The following is a description of a gene set: We sought to identify genes regulated by the transcription factor Th-POK (Zbtb7b) in liver Va14i NKT cells, by RNA microarray analysis of global gene expression in Va14i NKT cells from mice homozygous for the Th-POK-inactivating hd point mutation as compared with the same cell population isolated from heterozygous or wild-type age-matched mice. from publication Engel I, Zhao M, Kappes D, Taniuchi I, Kronenberg M (PMID 23034280) Genes down-regulated in Va14 invariant NKT cells: ZBTB7B knockout versus wildtype. species: Homo sapiens Human Gene Set: GSE34179_THPOK_KO_VS_WT_VA14I_NKTCELL_DN, and this is the list of marker genes: FSCN1, TM4SF4, KY, WWC1, LIF, ADM, IL2RA, EBF1, DPAGT1, MPEG1, CCT2, LAMC1, C3, PAK5, IRF8, MTHFD2, BCL11A, AKR1D1, TEKT2, PRKCSH, GADD45B, SUV39H2, NDFIP2, C6orf118, THOC1, FOS, CCDC159, ZNF473, H2AZ1, CA12, TCEAL8, CCNK, NCS1, TAF2, TFRC, BRCA1, HEPACAM2, VPREB1 (V-set pre-B cell surrogate light chain 1), POLR2G, SLC22A23, RRM2, DUT, ODF1, GLRX5, ATAD5, CCR8, TEFM, BCAP29, CCL4, PLEK, TOP2A, NR4A1, IL1RN, CTPS1, KCNF1, CYP11B2, TIMM8A, FNDC3B, EGR3, SPRY1 (sprouty RTK signaling antagonist 1), HAVCR1, CARMIL1 (capping protein regulator and myosin 1 linker 1), LAD1, BCAT1, TNFRSF13C, ZKSCAN8P1, DUSP5, ANKRD13C, BCL2L1, EGR1, SCARB1, TSPAN33, ESCO2, DNAH2, MLKL, TNNT2, HACD4, TXLNB, EFEMP1, TNFSF11, HELLS, ACKR3, EXOSC3, GATA1, NMRAL1, TAS2R4, VWF, DDC, CDK5R1, FAM167A, SNRPF, SLC3A2, PKIB, SOWAHC, GRM1, PLEKHO2, GOLGA3, TMEM64, CCL22, INHBE, ECT2, KCNC2, CALB1, UHRF1, INTS2 (integrator complex subunit 2), TMEM158, ZNF593, CISH, BHLHE40, TCERG1, TNFRSF9, VPS54, FA2H, EFHB, STAT5A, PAM, CCND2, PCLAF, SGO1, ANKRD33B, IPO5, CGAS, MYRF, HK2, GGCX, DHX37, KYNU, JPH1, ZNF354A, PMEPA1, WHRN, NR4A3 (nuclear receptor subfamily 4 group A member 3), ABCE1, TTBK1 (NCBI Gene Id 84630), TAF5L, CXCL3, TRIB1, ORAI1, MAGOH, CYP1A1, HSPA9, DDX25, PARD3, RIPK3, PPAN, SLC39A2, NDUFB6, PDCL2, EFHD1, ZKSCAN4, KARS1, PPARA, EIF3B, APEX2, CLIC4, PSAT1, FCER2, MAS1, PUS7, ACCSL, RASL10A, SULT4A1, C1orf53, ZNF281, STK32C, ACSL1, C17orf50, GBGT1, MREG, RASIP1, DENR, CD69, NDUFS3, NID1, ZFPM1, HOXD11, IRF4, MARCKS, MARCKSL1, CCDC112, HCAR2 (NCBI Gene Id 338442), TTLL10, ANXA4, CSF3, HIVEP3, CUL2, YRDC (NCBI Gene Id 79693), NTN4, TRIM45 (tripartite motif containing 45), MEDAG, EXO1, MEX3A, IL21, KLHDC2, CD83, C16orf46, UTF1, SLCO5A1, EGR2